The following is a description of a gene set: studied in species Mus musculus Mouse Gene Set: GOBP_NEGATIVE_REGULATION_OF_ORGANIC_ACID_TRANSPORT Any process that stops, prevents, or reduces the frequency, rate or extent of the directed movement of organic acids into, out of or within a cell, or between cells, by means of some agent such as a transporter or pore., and this is the list of marker genes: Grm7, Rgs2, Akt2, Acsl4, Prkg1, Gabbr1, Rgs4, Npy5r, Tnf, Abat, Akt1, Trh, Irs2, Atp5pf, Lep, Thbs1, Acacb, Hrh2, Hrh3, Arl6ip5, Htr6, Slc43a1, Slc43a2, Agtr2, Htr1b, Fis1, Htr1a, Adora1, Il1b, Il1rn, Pla2r1